The following is a description of a gene set: species: Homo sapiens Binding to a cytokine, any of a group of proteins that function to control the survival, growth and differentiation of tissues and cells, and which have autocrine and paracrine activity. Human Gene Set: GOMF_CYTOKINE_BINDING, and this is the list of marker genes: PARK7 (NCBI Gene Id 113880), CD36, CXCR6, COPS5, IL22RA1, IL22RA2, IL18R1, ACKR1, SOSTDC1, FGF2, ACKR4, LTBP1, ADAM17, CHRDL2, CHRD, CRLF1, IFNAR1, IL6R, CCR1, LTBP4, WFIKKN1, ITGAV, COMP, CSF2RA, ITGA4, CD74, CXCR4, IL12RB1, BMPR1A, ZFP36, ACKR2, ACKR3, BGN, TNFRSF14, IL2RG, TWSG1, BMPR1B, NRROS, TRIM16, CASP1, UCMA, IL1RL1, CCR6, TGFBR3L, GBP1, TCAP, CXCR2, IL31RA (NCBI Gene Id 386652), GREM2, HAX1, IL1R2, SOST, NRP2, IL10RA, VASN, TGFBR3, IL13RA1 (NCBI Gene Id 3597), OSMR, BMPR2, TGFBR1, IL12B, CRLF2, IL6ST, LRG1 (leucine rich alpha-2-glycoprotein 1), ACVRL1, CSF1R, TSKU (NCBI Gene Id 25987), CCR3, CXCR3, TRAF2, ITGB3, PXDN, IL1R1, IL20RA, IL18BP, IFNAR2, MMP8, IL11RA, IL1RN, LIFR, CX3CR1, SCUBE3, CCR9, NRP1, TNFRSF11A, HJV, IL2RB, XCR1, CD4, TGFBR2, LEPR, GREM1, ACVR1, IL17F, IL12A, MICOS10-NBL1, FZD4 (NCBI Gene Id 8322, frizzled class receptor 4), CNTFR, CCR7, IL12RB2, GDF5, CCR10, CXCR5, TNFRSF1A, IL36RN, PRLR, IL1RAPL1, PDPN, HMGB1, TNFRSF1B, GHR, ELANE, NLRP7, CCR4, TMC8, NBL1, ENG, KIT, A2M, IL20RB, THBS1, IL13RA2, CXCR1, IL3RA, HYAL2, IL5RA, PLP2, CCRL2, KLHL20, IL9R, CCR2, ITGB1, CHRDL1, IL23R, LRRC32, WFIKKN2, CSF3R, IFNGR1, CCR5, CER1, TGFB3, LTBP3, CCR8, IL2RA